The following is a description of a gene set: Any process that results in a change in state or activity of a cell (in terms of movement, secretion, enzyme production, gene expression, etc.) as a result of a stimulus indicating an increase or decrease in the concentration of solutes outside the organism or cell. species: Homo sapiens Human Gene Set: GOBP_CELLULAR_RESPONSE_TO_OSMOTIC_STRESS, and this is the list of marker genes: LRRC8C, ARHGEF2, RCSD1, CASP3, MTOR, TSPO, STK39, PTGS2, SLC2A4, AQP1, NLRP3, ERRFI1, LRRC8D, NLK (nemo like kinase), TRPV4, CLCN2, SLC4A11, ZFP36L1, PYCARD, SLC2A1, WNK1, YBX3, BDKRB2, FBP1, EFHD1, SERPINB6, CAB39, SCN2A, EPO, MICU1, TRPV3, SLC12A6 (solute carrier family 12 member 6), OXSR1, RPTOR, ATP1A1, FXYD2, NFAT5, USP15, TIFAB, AKR1B1, SLC25A23, LETM1, VPS13A, MYLK, CASP1, PKD2 (polycystin 2, transient receptor potential cation channel), WNK3, NINJ1, ABCB1 (ATP binding cassette subfamily B member 1), ZFAND1, DDX3X, MLST8, XRCC6, AQP5, LRRC8E, CLN3, BAD, RELB, CAPN3, SCN7A